Given this list of marker genes OSBP2, HBG1, CA1, SELENBP1, CHST2, AHSP, TFR2, GAL, FGFR4, FAM178B, IGFBP5, PLXNA2, TRIB2 (tribbles pseudokinase 2), ADD2, GYPA, NFIA, GYPB, GYPE, PNMT, PKLR, DPP4, HBG2, DHRS9, here is a description of the gene set: Human Gene Set: XIE_ST_HSC_S1PR3_OE_DN Genes downregulated in short-term hematopoietic stem cells (CD34+,CD38_,CD45RA_,CD90_,CD49f_) upon overexpression of Sphingosine-1-Phosphate Receptor 3 (S1PR3) Acute myeloid leukemia (AML) is a caricature of normal hematopoiesis driven from leukemia stem cells (LSC) that share some hematopoietic stem cell (HSC) programs including responsiveness to inflammatory signaling. Although inflammation dysregulates mature myeloid cells and influences stemness programs and lineage determination in HSCs by activating stress myelopoiesis, such roles in LSCs are poorly understood. Here, we show that S1PR3, a receptor for the bioactive lipid sphingosine-1-phosphate, is a central regulator that drives myeloid differentiation and activates inflammatory programs in both HSCs and LSCs. S1PR3-mediated inflammatory signatures varied in a continuum from primitive to mature myeloid states across cohorts of patients with AML, each with distinct phenotypic and clinical properties. S1PR3 was high in LSCs and blasts of mature myeloid samples with linkages to chemosensitivity, whereas S1PR3 activation in primitive samples promoted LSC differentiation leading to eradication. Our studies open new avenues for therapeutic target identification specific for each AML subset.<BR/>Significance: S1PR3 is a novel regulator of myeloid fate in normal hematopoiesis that is heterogeneously expressed in AML. S1PR3 marks a subset of less primitive AML cases with a distinct inflammatory signature and therefore has clinical implications as both a therapeutic target and a biomarker to distinguish primitive from mature AML. from publication Xie SZ, Kaufmann KB, Wang W, Chan-Seng-Yue M, Gan OI, Laurenti E, Garcia-Prat L, Takayanagi SI, Ng SWK, Xu C, Zeng AGX, Jin L, McLeod J, Wagenblast E, Mitchell A, Kennedy JA, Liu Q, Boutzen H, Kleinau M, Jargstorf J, Holmes G, Zhang Y, Voisin V, Bader GD, Wang JCY, Hannun YA, Luberto C, Schroeder T, Minden MD, Dick JE (PMID 33458693) studied in species Homo sapiens